The following is a description of a gene set: studied in species Homo sapiens Human Gene Set: KEGG_MEDICUS_REFERENCE_ALTERNATIVE_PATHWAY_OF_COMPLEMENT_CASCADE_C3B_BREAKDOWN Pathway Definition from KEGG: (C3b+Bb) -- (CFH,(CD55+CR1)) -> C3b -- (CFI+(CFH,CR1,CD46)) -> iC3b -- (CFI+CR1) -> C3dg -- Plasmin -> C3d Alternative pathway of complement cascade, C3b breakdown. Pathway ID: N01496. Pathway type: Reference. Pathway class: nt06513 Complement cascade., and this is the list of marker genes: CR1, CFI, CFH, CD46, CD55